The following is a description of a gene set: Genes predicted to be targets of miRBase v22 microRNA hsa-miR-549a-5p in miRDB v6.0 with MirTarget v4 prediction scores > 80 (high confidence targets). from publication Chen Y, Wang X (PMID 31504780) Human Gene Set: MIR549A_5P studied in species Homo sapiens, and this is the list of marker genes: NEDD9, TSPAN9, LYRM1, PAN3, ZNF331, TMEM132E-DT, ANO6, CECR2, PRKCI, SSX2B, CAV2, SSX1, EXT1, SSX7, DLC1, MTSS1, NR1D1, FAM216B, PDE4B, DNAAF9, RPTN, RAI14, RANBP3, PPP1R3C, C8orf34, SIRPB1, SSX3, CASQ1, ABRAXAS2, AGA, PPP2CB, CNOT2, GABPB2 (GA binding protein transcription factor subunit beta 2), ATP6V0A2, MTURN, C18orf63, SMS, ZNF605, PSMA2, SLC12A8, CHST8, ACTB, SEPTIN2, OSBPL8, GRHL2, ASB2, NDC1, FOSL1, SSX2, AMACR, SMURF1, SSX5, GP5, METTL23